The following is a description of a gene set: This event has been computationally inferred from an event that has been demonstrated in another species.<p>The inference is based on the homology mapping from PANTHER. Briefly, reactions for which all involved PhysicalEntities (in input, output and catalyst) have a mapped orthologue/paralogue (for complexes at least 75% of components must have a mapping) are inferred to the other species. part of: PIP3 activates AKT signaling Reactome Pathway: PTEN Regulation electronically inferred by orthology from the curated human pathway studied in species Mus musculus, and this is the list of marker genes: Psma1, Psmc2, Psmc5, Cbx8, Psmb7, Ring1, Rragc, Psma3, Wwp2, Psmc6, Sall4, Rps27a, Maf1, Otud3, Psmb5, Psmd7, Psma7, Rnf146, Psma4, Lamtor2, Psma2, Cbx4, Psmb6, Cbx6, Psmd12, Ubb, Ezh2 (enhancer of zeste 2 polycomb repressive complex 2 subunit), Psmc4, Rbbp4, Lamtor4, Mbd3, Psmc1, Psma6, Scmh1, Bmi1, Trim27, Rheb, Lamtor1, Mta2, Psmb4, Psmd6, Csnk2b, Tnks2, Rbbp7, Cbx2, Psmc3 (proteasome (prosome, macropain) 26S subunit, ATPase 3), Psma5, Rraga, Mta1, Phc1, Lamtor5, Psmd1, Psmd13